Given this list of marker genes PTPRD, NIFK (NCBI Gene Id 84365), DCUN1D4, DMD, ARRB1, WAC, RNF20, SPOP, AAK1, SERPINB7, METTL2A, GOT2, ZDBF2, PARVG, RBP3, NSUN5, IFIT3, ADCYAP1R1, DYRK1A, KIF20A, DDX39B, IFNA16, MCL1, LPP, IRF6, KCNJ3, DIP2C, LOXL3, GATA1, DDB1, EGFR, MYH11, DPP3, SNAP25, METTL2B, SIRPA, SERPINB9, CLDN3, MOB3B, IQSEC2, KCNMA1, PRR5L, ST3GAL6, HOPX, TRABD2B, PPIA, KCND2, BMERB1, SBF2, SENP1, ZNF623, PBLD, EHD1, FAM89A, IFNA7, ABCA13, DPH6, UBTF, SEPTIN7, TTC39C, IL20, CAPN6, JAG2, RGS6, TEX28, RBBP6, PRR9, AMD1 (adenosylmethionine decarboxylase 1), CABYR, YWHAE, GLS2, IFNA17, XKR6, DYNLT1, DIPK2A, CADM4, CCDC43, ZNF547, ELSPBP1, AK9 (NCBI Gene Id 401271), RDX, OLFM3 (NCBI Gene Id 118427), PVR, FAT1, IFNA4, NKD2, PLAG1, BTG1, IFNA14, WDFY3, FNDC3B (fibronectin type III domain containing 3B), here is a description of the gene set: Genes predicted to be targets of miRBase v22 microRNA hsa-miR-876-3p in miRDB v6.0 with MirTarget v4 prediction scores > 80 (high confidence targets). from publication Chen Y, Wang X (PMID 31504780) studied in species Homo sapiens Human Gene Set: MIR876_3P